The following is a description of a gene set: Genes up-regulated in polarizing CD4 Th17 cells: wildtype versus RORC knockout. from publication Huh JR, Leung MW, Huang P, Ryan DA, Krout MR, Malapaka RR, Chow J, Manel N, Ciofani M, Kim SV, Cuesta A, Santori FR, Lafaille JJ, Xu HE, Gin DY, Rastinejad F, Littman DR (PMID 21441909) Human Gene Set: GSE27241_WT_VS_RORGT_KO_TH17_POLARIZED_CD4_TCELL_UP CD4+ T helper lymphocytes that express interleukin-17 (Th17 cells) have critical roles in mouse models of autoimmunity, and there is mounting evidence that they also influence inflammatory processes in humans. Genome-wide association studies in humans have linked genes involved in Th17 cell differentiation and function with susceptibility to Crohn’s disease, rheumatoid arthritis, and psoriasis1-3. Thus, the pathway towards differentiation of Th17 cells and, perhaps, of related innate lymphoid cells with similar effector functions4, 5, is an attractive target for therapeutic applications. Mouse and human Th17 cells are distinguished by expression of the retinoic acid receptor-related orphan nuclear receptor RORγt, which is required for induction of IL-17 transcription and for the manifestation of Th17-dependent autoimmune disease in mice6. By performing a chemical screen with an insect cell-based reporter system, we identified the cardiac glycoside digoxin as a specific inhibitor of RORγt transcriptional activity. Digoxin inhibited murine Th17 cell differentiation without affecting differentiation of other T cell lineages and was effective in delaying the onset and reducing the severity of autoimmune disease in mice. At high concentrations, digoxin is toxic for human cells, but non-toxic synthetic derivatives, 20,22-dihydrodigoxin-21,23-diol (Dig(dhd)) and digoxin-21-salicylidene (Dig(sal)), specifically inhibited induction of IL-17 in human CD4+ T cells. Using these small molecule compounds, we demonstrated that RORγt is imporant for the maintenance of IL-17 expression in mouse and human effector T cells. These data suggest that derivatives of digoxin can be used as chemical probes for development of RORγt-targeted therapeutic agents that attenuate inflammatory lymphocyte function and autoimmune disease. species: Homo sapiens, and this is the list of marker genes: H4C9, H1-5, BARD1, PHGR1, PRC1, TTK, KIF14, ARHGAP19, INTS10, SHC1, TROAP, FYN, BRIP1, FUBP1, ALYREF, POLE, RAB27A, JAZF1, CENPF, H2AC25, DUSP6, RNF152, WSCD1, KNTC1, PLK1, TAAR3P, NEIL3, DCPS, ARHGAP11A, FAF1, BMP7, ANAPC5, RNF26, TOP2A, TMPO, DNA2, SMC2, STMN1, AARSD1, TTF2, GDF10, CDC6, RPS12, ALCAM, FGF13, PODXL2, PPP1CA, H1-3, CTNNAL1, INCENP, JUP, CDCA8, ITGA6, H2AZ2, UHRF1, BUB1B, KIF15, RACGAP1, E2F8, SPSB1, KNL1, NUP205, ANLN, CDCA2, KIF4A, HMGB3, KIF22, ARC, CKAP2L, IL24, PIK3R3, HASPIN, XRCC2, TOX, LPO, TACC3, EZH2, KIF18B, RPSA, FANCD2, UBE2T, RPL39, TCERG1, SLC16A2, POLQ, POP1, CENPS (centromere protein S), NCAPD2 (NCBI Gene Id 9918), NEURL1B, ECT2, PLXNB3, RFWD3, CCNA2, DUSP4, PTCHD3, INSL5, NCAPH, H1-1 (NCBI Gene Id 3024), MCM10, ESCO2, MIS18BP1, RBM24, CCNF, SEC61G (SEC61 translocon subunit gamma), PRR11, KIF23, LIN54, NCAPG2, ABI2, RNASE12, NTN1, PIF1, RAD54B, ZRANB3, PPIG (peptidylprolyl isomerase G), H2BC9, HOXA5, GTSE1, CKAP5, MEX3C, H2BP2, H4C4, H2BC26, ARSI, CENPE, H2BC3, SARS2, UBE2S, MNS1, TPX2, LIG1, NFKBID (NCBI Gene Id 84807), MCAM, SLC22A15, CHTF18 (chromosome transmission fidelity factor 18), C3orf22, CENPJ, MYBL1 (MYB proto-oncogene like 1), NSD2, PSCA, FBLN1, STAG3, CDC25B, SMOC1, BCOR, AKAP1, KIF11, NUCKS1, MKI67, EGR1, HDGF, ATAD2, BRCA1, GMNN, SUMO2, SPAG5, AKAP12, RBL1 (RB transcriptional corepressor like 1), PDE7A, HNMT, ASPM, FMNL3, GFI1B